The following is a description of a gene set: Genes predicted to be targets of miRBase v22 microRNA mmu_miR_7685_3p in miRDB v6.0 with MirTarget v4 prediction scores > 80 (high confidence targets). Mouse Gene Set: MIR_7685_3P from publication Chen Y, Wang X (PMID 31504780) studied in species Mus musculus, and this is the list of marker genes: Tmem263, Atp11b, Abcb1a, Nkain3, Tmem170b, Efna4, Niban2, Kcna6, Megf11, R3hdm1, Slc26a3, Gpr34, Eif4g2, Slc34a2, Slc35e2, Adcy1, Mecp2, Sema6d, Hdgfl3, Acss1, Plppr2, Serpinb3c, Epb41l2 (erythrocyte membrane protein band 4.1 like 2), Mpz, Cacnb2, Hsph1 (NCBI Gene Id 15505), Ubtfl1, Cadm1, Rab21, Plpp7, Chic1, Zfhx4, Gpr3, Fhl4, Mier1, Med12, Pde12, Idnk, Tmem150c, Mb (myoglobin), Clic5, Cd163, Maco1, Tmem161b, Spata31g1, Mea1, Frmd7